Given this list of marker genes Pik3r5, Pik3r1, Pik3c3, Nrbf2, Pik3r4, Atg14, Pik3r3, Uvrag, Becn2, Pik3cg, Pik3r6, Becn1, Pik3ca, Pik3cd, Pik3cb, Pik3r2, here is a description of the gene set: A protein complex capable of phosphatidylinositol 3-kinase activity and containing subunits of any phosphatidylinositol 3-kinase (PI3K) enzyme. These complexes are divided in three classes (called I, II and III) that differ for their presence across taxonomic groups and for the type of their constituents. Catalytic subunits of phosphatidylinositol 3-kinase enzymes are present in all 3 classes; regulatory subunits of phosphatidylinositol 3-kinase enzymes are present in classes I and III; adaptor proteins have been observed in class II complexes and may be present in other classes too. Mouse Gene Set: GOCC_PHOSPHATIDYLINOSITOL_3_KINASE_COMPLEX species: Mus musculus